The following is a description of a gene set: from publication Abbas AR, Baldwin D, Ma Y, Ouyang W, Gurney A, Martin F, Fong S, van Lookeren Campagne M, Godowski P, Williams PM, Chan AC, Clark HF (PMID 15789058) Immune cell-specific expression is one indication of the importance of a gene's role in the immune response. In order to identify such patterns, we set out to broadly profile gene expression in a variety of immune cells. Genes up-regulated in comparison of neuthrophils versus monocytes. Human Gene Set: GSE22886_NEUTROPHIL_VS_MONOCYTE_UP studied in species Homo sapiens, and this is the list of marker genes: DUOX1, SLC5A1, MAGEA3, FGL1, ELAPOR1, UBE2D4, RIMS2, ANGPTL7, KCNJ5, GPR63, HTN3, ST7L, FAM163A, LRRC1, ZNF816, NR5A2, MEFV, LHX6, ZDHHC18, OVOL2, RLBP1, CABP5, TNFSF18, SMIM27, RGN, CRP, OPHN1 (NCBI Gene Id 4983), MAGEC2, IL5RA, PTGDR2, FOXA1, VGF, BACE2, KRT23, PROZ, KRT35, SLC18A2, POU2AF1, PYGM, KITLG, HAO2, SLC49A3, FRAS1, BUB1, ADAM18, ALOXE3, CXCR1, OGDHL, CALCA, TJP1, RUBCNL, NLGN4X, MID2, ITGA2, MTAP, GAL, CD2, MCF2L, CYP4F3, ETV1, ALDOB, MAP1LC3C, TUFT1, DAO, AQP2, SOX3, SLPI, HCN4, KCNJ15, HMGB3P1, CBLN1, MATN1, MME, SERHL2, SCARA3, ADGRG3, NRCAM, CT55, TAAR2, CDH12, PCP4, TREML2, NR0B2, EPHB1, KATNBL1, CPA2, GRIK2, SERPINA6, S100A7, LGI2, ZNF507, TTC39A, TENT5C, LCT, TNFRSF10C (TNF receptor superfamily member 10c), ANXA3, KIAA1614, TDRD12, CIT, KLRD1, MCTP2, DNAH3, DPEP3, E2F1, PRKD1, LTB, CHST3, H1-2, CEP72, LAMP5, OR2W1, RNF17, PNO1, KRT37, MAGEL2, RECK, ALX1, CA4, MANSC1, IL2RB, PLOD2, CYP2B7P, IL9R, MYCBP, HCG4B (HLA complex group 4B), LIFR, SIGLEC8, SCAND2P, FFAR2, CCR3, BCO1, EFHC2, CTTN, INSL5, PGPEP1, KIR2DL4, GLRB, DDX4, SCD5, NPAS3, NPY4R, CLC, CEACAM1, MYO10, TMEM40, MAP2, GPATCH4, CSN1S1, SLC22A17, PRF1, ERCC6L, CEACAM3, CLIC5 (chloride intracellular channel 5), CHRNA3, HSPB2, ST20, ADAM20, PTPRJ, TFCP2L1, PHC2, AMBP, RHPN1-AS1 (RHPN1 antisense RNA 1 (head to head)), ITIH5, PARD3, RGS4, CHP2, RAB11FIP5, PHF7, NECAB2, ZNF552, SLITRK2, GFM1, NOL4, DEFA6, ANXA13, CLCN4, H3C10, COL4A3, TCN1, CXCR2, MAGEA6, KCNA4, KIR3DL1, PSG6 (pregnancy specific beta-1-glycoprotein 6), MAK (male germ cell associated kinase), CCNJL, SLC39A2, HOPX, DLC1, CCR9, USP10, PDCD4-AS1, GPLD1, SNAP91 (synaptosome associated protein 91), FOXM1, SLC24A3, VCAM1